The following is a description of a gene set: A multisubunit barrel shaped endoprotease complex, which is the core of the proteasome complex. studied in species Mus musculus Mouse Gene Set: GOCC_PROTEASOME_CORE_COMPLEX, and this is the list of marker genes: Psmb10, Psma3, Psma5, Psma8, Psmb8, Psma4 (proteasome subunit alpha 4), Psmb11, Psma1, Psmb3, Psmb7 (proteasome (prosome, macropain) subunit, beta type 7), Psmb5, Psmb4, Psma7, Psmb2, Psma6, Psma2, Psmb1, Psmb6 (NCBI Gene Id 19175), Psmb9